Given this list of marker genes SLC25A33, SLC25A32, LRRC8D, SLC25A6, SLC25A4, SLC35B3, LRRC8A, SLC35B2, SLC25A53, LRRC8C, SLC46A2, LRRC8E, SLC25A47, SLC17A9, SLC19A1, SLC25A5, SLC25A41, SLC25A17, SLC25A36, SLC25A51 (solute carrier family 25 member 51), SHOC2, ADCY10, SLC25A31, SLC25A23, SLC25A24, ABCC4, SLC25A52, LRRC8B, here is a description of the gene set: Human Gene Set: GOBP_NUCLEOTIDE_TRANSMEMBRANE_TRANSPORT species: Homo sapiens The directed movement of nucleotide across a membrane.